The following is a description of a gene set: from publication Fu W, Ergun A, Lu T, Hill JA, Haxhinasto S, Fassett MS, Gazit R, Adoro S, Glimcher L, Chan S, Kastner P, Rossi D, Collins JJ, Mathis D, Benoist C (PMID 22961053) studied in species Homo sapiens The transcription factor FoxP3 partakes dominantly in the specification and function of FoxP3+ CD4+ T regulatory cells (Tregs), but is neither strictly necessary nor sufficient to determine the characteristic Treg transcriptional signature. Computational network inference and experimental testing assessed the contribution of several other transcription factors (TFs). Enforced expression of Helios or Xbp1 elicited specific signatures, but Eos, Irf4, Satb1, Lef1 and Gata1 elicited exactly the same outcome, synergizing with FoxP3 to activate most of the Treg signature, including key TFs, and enhancing FoxP3 occupancy at its genomic targets. Conversely, the Treg signature was robust to inactivation of any single cofactor. A redundant genetic switch thus locks-in the Treg phenotype, a model which accounts for several aspects of Treg physiology, differentiation and stability. Human Gene Set: GSE40274_FOXP3_VS_FOXP3_AND_HELIOS_TRANSDUCED_ACTIVATED_CD4_TCELL_DN Genes down-regulated in CD4 T conv over-expressing: FOXP3 versus IKZF2 and FOXP3., and this is the list of marker genes: HLCS, EFCAB3 (NCBI Gene Id 146779), MYB, SRRM1, KAT6B (NCBI Gene Id 23522), PPP4R3A, ZRANB1, NCLN, TUT7, CAMTA1, HAO2, LYST, NLRC3, SKIL, RAPGEF4, IZUMO1R (IZUMO1 receptor, JUNO), WDR75, MLLT11 (MLLT11 transcription factor 7 cofactor), TBC1D8B, ZMYM5, SNORA3A (NCBI Gene Id 619562), CLCF1, ZBTB20, HEXD, NAA15, MTCP1, MIR499A, KDM7A, LINC-PINT, ARFGEF1, RER1, ARID4A, RMDN1, SLAMF6, ARAP2, GPR183, CEP350, MLLT10, MIR301B, SLC10A1, CCNYL1, TMEM18, SCARNA13, KRT5, ARL6IP4, INTS6L, SMC4, SLC6A19, CPT1A, SNORA23, MPHOSPH9, DNAJB7, PRDM2, BOD1L1, KAT2B, RSRC2, CNR2, AIM2, TIAL1, REV3L, IL10RA, MSI2, KRIT1 (KRIT1 ankyrin repeat containing), CPSF6, ANKRD28, KBTBD3, PNPLA8, TIRAP, PARP6 (poly(ADP-ribose) polymerase family member 6), HECTD1, KIF18A, SOCS6, NFKBIA, P2RX7, TXNDC16, SNORA74A, GPRASP3, AKAP13, SNAPC4, FASTKD3, PRMT3, TTBK2, NFE2L2, ZFP1, SNORA73B, SKAP2, FBXO4, KIN, FOXP1, IL6, SLC14A1 (solute carrier family 14 member 1 (Kidd blood group)), MME, CD55 (CD55 molecule (Cromer blood group)), ITPR2, SNORA28, CLOCK, PCF11 (NCBI Gene Id 51585), PAIP1, ERBIN, TNFSF8, CNOT7, TRAPPC6B, NSG2, RGN, TWF1, AP4B1, SLC15A2, TMC6, TUG1, RFLNB, GPR151, MTERF2, PAN3, GALNT11, PPIL4, RIF1, PRKCE, VPS54, RDH5, H1-3, ZCCHC7, CEP83, SCFD1, SAP130, RAD50, ROCK1, DTX3, SMIM29, MGAT4B, AKAP11, TMEM175, IL18BP, TRIM34, HPS3, TMEM126A, SMAD5, MIR103A2, SLC37A3, FAS, KCMF1, TREML2, TMEM87B, CHD1